Given this list of marker genes GLRB, SLC30A6, FBXL8, MNAT1, FAM98C, CHD9, TMEM229B, CASP7, PRM3, FOXN3, ETFRF1, ARF4, ATRNL1, GAMT, AGA, INO80, SHC3, YPEL3, CLEC5A, DPH6, RBM6, PRKCA, TMEM215, FAM135A, CWC15, COPB1, DAGLB, TSHZ3, TGFBR1, ARPC1A, FOXE3, HECA, SCAND1, DUSP26, XIAP, C9orf43, MED30, TPST1, CYP2C8, SPESP1, PCMTD1, SCAMP2, SF3B5, RELCH, ING3, ZNF536, ABT1, METTL6, GPM6A, AKAP5, ZNF655, TRPV1, EPS8L1 (NCBI Gene Id 54869), SMPDL3A, SRSF6, TMEM223, NAT1, SHLD1, POF1B, UCHL5, NEB, MRPS34, ASF1A, LZTFL1, POU6F1, GMEB2, MGAT5, PARP1, NR2E3 (nuclear receptor subfamily 2 group E member 3), FUCA1, NCKAP1 (NCK associated protein 1), TINF2, TMEFF1, KANSL2, LYPLA1, ZMAT5, RPGR, AIFM2, MKNK2, PKP3, CLEC12B, HSCB, ZNF14, ANTKMT, AP5M1, CCDC12, YDJC, CZIB, PTN, BAG6, ISOC1 (NCBI Gene Id 51015), TMEM71, RFXANK, TMEM30A-DT, MTMR11, ADGRE5, CYB561D2, ATCAY, RASGRF2, ATPAF2, MIPOL1, SBSN, OMP, ASAP3, NDUFB8, ETHE1, SNX9, ARB2A (NCBI Gene Id 83989), VPS39, AKAP4, PIK3CG, CCDC186, ARL6IP4, CD274, MRPL15, ITGAM, OST4, ERO1A, BUB1B, SLC25A36, TH, DARS2, PSMD1, ENPP1, TAF5, SLC41A2, PLAG1, SPATA18, ANAPC2, SELENOH, INO80E (NCBI Gene Id 283899, INO80 complex subunit E), SNX20, PPP1R3G, STK26 (serine/threonine kinase 26), FBLN7, RBFOX1, CCDC32, TSC22D4, ATP5ME, IKBKG, C6orf118, DEF6, KAT5, NALF1, EXOC4, CIMIP6, SLC35A4, SH2D4A, TUBB6, TBCCD1, MAD2L1BP, TAF2, PSMD14, TSPYL4, PRPF3, GCSH, SNAPIN, FAM204A, BMPER, SLC2A9, RPS25, FAM91A1, FGFRL1, SERP1, RPS6KA2, MND1, ANKRD46, ANKRD13B, PCCA, TMEM86B, EYA2, TCP11L2, RCCD1, CD300C, ZNF395, CDK2AP2 (NCBI Gene Id 10263), SIN3A, MPHOSPH9, TXNDC5, ASAH2 (NCBI Gene Id 63292), ZNF18, GNAS, NGEF, SIPA1L1, KLK9, DMAC2, ITGB2, MRPL22, GSTM4, ACTR5, UGT2A3, MATN2, BOLA2, NKX2-2, STX5, MAPKAPK3, TNFRSF21, LHFPL6, PGAP4, GNA14, here is a description of the gene set: Th1 and Th2 cells arise from a common precursor cell in response to triggering through the TCR and cytokine receptors for IL-12 or IL-4. This leads to activation of complex signaling pathways, which are not known in detail. Disturbances in the balance between type 1 and type 2 responses can lead to certain immune-mediated diseases. Thus, it is important to understand how Th1 and Th2 cells are generated. To clarify the mechanisms as to how IL-12 and IL-4 induce Th1 and Th2 differentiation and how TGF-beta can inhibit this process, we have used oligonucleotide arrays to examine the early polarization of Th1 and Th2 cells in the presence and absence of TGF-beta after 0, 2, 6 and 48 hours of polarization. Genes up-regulated in CD4 T cells: untreated (0h) versus activated by anti-CD3 and anti-CD28 and then stimulated by TGFB1 and IL-12 (48h). studied in species Homo sapiens Human Gene Set: GSE2770_UNTREATED_VS_TGFB_AND_IL12_TREATED_ACT_CD4_TCELL_48H_UP from publication Lund R, Aittokallio T, Nevalainen O, Lahesmaa R (PMID 14607935)